Given this list of marker genes GP1BA, F2, ITGB3, F8, GP1BB, CDC42BPB, ITGA2, ITGA2B, AXIN1, CD109, here is a description of the gene set: studied in species Homo sapiens Hemorrhage between the skull and periosteum of a newborn resulting from rupture of blood vessels that cross the periosteum. Human Gene Set: HP_CEPHALOHEMATOMA Cephalohematoma